The following is a description of a gene set: Mouse Gene Set: GOBP_ICOSANOID_BIOSYNTHETIC_PROCESS The chemical reactions and pathways resulting in the formation of icosanoids, any of a group of C20 polyunsaturated fatty acids. studied in species Mus musculus, and this is the list of marker genes: Tbxas1, Edn2, Ptgds, Pla2g5, Cyp4a12b, Il1b, Lta4h, Avpr1a, Alox5ap, Ptgs2, Pla2g4f, Pibf1, Daglb, Hpgds, Cyp4a10, Ptgs1, Prxl2b, Ggt5, Cyp2c23, Alox5, Syk, Mgst3, Fabp5, Cyp4a30b, Mgst2, Pla2g2a, Edn1, Pnpla8, Prg3, Ptges, Mapk9, Abcc1, Cyp4a31, Cthrc1, Ptges3-ps, Sirt1, Anxa1, Mif, Ptges2, Ltc4s, Fcer1a, Pla2g10, Cyp4a12a, Sco1, Avp, Sphk1, Cyp4a14, Ptgis, Pla2g4a, Cyp4a29, Pla2g3, Ptges3, Cd74 (CD74 antigen (invariant polypeptide of major histocompatibility complex, class II antigen-associated)), Cyp4a32